Given this list of marker genes ACTN2, AHCYL1, ROCK1, PPP3CA, PRKCA, MAS1, CAMK2A, SRC, AGTR1, ACE, ROCK2, CA2, MIR143, AGT, AGTRAP, MIR145, RAP1GDS1, PLA2G2A, FAM114A1, RAC1, AGTR2, CAV1, SLC26A6, here is a description of the gene set: Human Gene Set: GOBP_ANGIOTENSIN_ACTIVATED_SIGNALING_PATHWAY A G protein-coupled receptor signaling pathway initiated by angiotensin II binding to its receptor on the surface of a target cell, and ending with the regulation of a downstream cellular process, e.g. transcription. studied in species Homo sapiens